Given this list of marker genes SQOR, GMPR, HLA-C, CMTR1, IFI44, PCNX1, PLSCR1, MSX1, TTC39A, MAP2, DDX60, STARD5, RPS18, ENO3, JAK2, UBA7, ETV7, USP18, OASL, GBP1 (NCBI Gene Id 2633), GLB1L2 (galactosidase beta 1 like 2), TRAFD1 (NCBI Gene Id 10906), TENT5A, HERC6, LGALS8, TAP2, LGALS9, SHFL, PSME1, PDZD2, BTN3A3, SPTLC2, IFI35, ISG15, TLE4, OGFR, SETX, ZCCHC2, ZFPM2, ACOT9, GMDS, PSMB9, BCL2L13, SAMD9, SIAH2, TMEM62, LAP3, BAK1, CASP7, MFSD12, IL7, PMAIP1, BLZF1, ARID5A, IFIT5, SLFN12, RIPK1, TRIM38, IRF2, CBR3, SP100, STAT2, HLA-J, FBXL7, SLC25A28, KCTD14, CX3CL1, BAG1, N4BP1, EIF2AK2, PLEKHA4, PCF11, IL15RA, TRIM21, OAS2, APOL6, PROX1, IFIH1, KCNJ12, PSME2, JADE2, IRS1, IFI6, SAMHD1, PIGL, SPSB1, APOL1, RIPK2, ELF1, TRIM14, CD47 (CD47 molecule), MYD88, CSF1, RNF19B, MALT1, SP110, PSMA6, FUT4, CEACAM1, KATNIP, HLA-A, SIDT2 (NCBI Gene Id 51092), CYLD, LY6E, RCAN1, USP25, PHF11, TAP1, PLAAT4, GSDMD, TRIM26, HLA-F, WARS1 (tryptophanyl-tRNA synthetase 1), IRF9, ADAR, ART3, ACSL5, CALCOCO2, THEMIS2, NF1, IRF1, MCL1, DNAJA1, TLR3, XAF1, FHL3, PRKD2, PML, KANSL1L, CCL8, SCYL3, UBE2L6, ELF4, APOBEC3G, TNKS2, MEF2C, IFI30, TRIM22, IFI44L, CTNNBL1, TREX1, APOL2, CNP, C1R, SPATS2L, RHBDF2, PSMB10 (NCBI Gene Id 8138), PLA1A, RBM7, SP140L, IFIT2, IFIT1, CXCL11, BAZ2A, NMI, STAT1, HLA-B, GOLM1, CASP1, IFIT3, NAPA, TDRD7, PSMB8, NDUFA9, IDO1, RSAD2, IRF7, BTN3A1, HERC5, MAK, PARP12, GCH1, MX1, TYMP, APOL3, CYP2J2, DHX58, RTP4 (receptor transporter protein 4), SECTM1, ZFYVE26, MCUB, VEZF1, TRANK1, YEATS2, SLC15A3, MX2, TMEM268, RAB9A, OAS1 (2'-5'-oligoadenylate synthetase 1), GTF2B, FAM20B, ISG20, CASP10, CXCL10, XIAP, OAS3, FES, RIGI, here is a description of the gene set: We identified Pparg as a major orchestrator of the phenotype of adipose-tissue resident regulatory T cells (VAT Tregs). To explore the contribution of Pparg1 and 2 in the generation of the VAT Tregs-specific gene signatures, CD4+FoxP3- T cells were transduced with Foxp3+/- Pparg1 (or Pparg2), treated with Pioglitazone or vehicle, and double sorted for microarray analysis. from publication Cipolletta D, Feuerer M, Li A, Kamei N, Lee J, Shoelson SE, Benoist C, Mathis D (PMID 22722857) Human Gene Set: GSE37533_PPARG2_FOXP3_VS_FOXP3_TRANSDUCED_CD4_TCELL_DN Genes down-regulated in CD4 over-expressing: FOXP3 and PPARg2 form of PPARG versus FOXP3. species: Homo sapiens